The following is a description of a gene set: Human Gene Set: GOMF_FOUR_WAY_JUNCTION_HELICASE_ACTIVITY Unwinding a DNA helix of DNA containing four-way junctions, including Holliday junctions, driven by ATP hydrolysis. species: Homo sapiens, and this is the list of marker genes: FANCM, RECQL5, WRN, RECQL4, BLM, RECQL